Given this list of marker genes ARSA, OBSCN (NCBI Gene Id 84033), MT-CO1, GLA, MT-CO3, HEXB, MCOLN1, KHK, PSAP, GM2A, HEXA, LPIN1, here is a description of the gene set: species: Homo sapiens Human Gene Set: HP_ABNORMALITY_OF_GLYCOLIPID_METABOLISM An abnormality of glycolipid metabolism. Abnormality of glycolipid metabolism